The following is a description of a gene set: studied in species Homo sapiens In addition to the better characterized COPI-dependent retrograde Golgi-to-ER pathway, a second COPI-independent pathway has also been identified. This pathway is RAB6 dependent and transports cargo such as glycosylation enzymes and Shiga and Shiga-like toxin through tubular carriers rather than vesicles. In the absence of a COPI coat, the membrane curvature necessary to initiate tubulation may be provided through the action of phospholipase A, which hydrolyzes phospholipids at the sn2 position to yield lysophospholipids. This activity is countered by lysophospholipid acyltransferases, and the balance of these may influence whether transport tubules or transport vesicles form (de Figuiredo et al, 1998; reviewed in Bechler et al, 2012). RAB6-dependent tubules also depend on the dynein-dynactin motor complex and the hoomodimeric Bicaudal proteins. part of: Golgi-to-ER retrograde transport Reactome Pathway: COPI-independent Golgi-to-ER retrograde traffic, and this is the list of marker genes: TUBA1A, ACTR1A, DCTN5, DYNC1I1, CAPZA1, DYNC1I2, DYNC1H1, TUBB4B, TUBB8B, GALNT2, DCTN2, DYNLL2, TUBA4A, TUBB3, TUBA1B, GALNT1, RAB18, BICD2, CAPZA3, TUBA3D, TUBB6, RAB3GAP2, TUBAL3, DCTN4, DYNC1LI2, TUBB2B, CAPZA2, TUBB2A, DCTN1, DYNLL1, RAB6A, TUBA3E, CAPZB (NCBI Gene Id 832), BICD1, RAB3GAP1, DCTN6, RAB6B, ACTR10, PAFAH1B3, TUBB1, PAFAH1B2, TUBA1C, DYNC1LI1, PAFAH1B1, DCTN3, TUBA3C, TUBA4B, PLA2G6, TUBA8, TUBB4A, PLA2G4A (NCBI Gene Id 5321), AGPAT3, TUBB8